The following is a description of a gene set: Human Gene Set: HP_CONCAVE_NASAL_RIDGE Concave nasal ridge Nasal ridge curving posteriorly to an imaginary line that connects the nasal root and tip. species: Homo sapiens, and this is the list of marker genes: NFKBIA, POU1F1, FBXL4, KDF1, DDR2, ZEB2, RECQL4, HSPG2, SOST, IL2RA, CANT1, IGF1, ANTXR1, DMXL2, FOXC1, STAT5B, EXOSC2 (NCBI Gene Id 23404), NIPBL, JAG1, PEPD, ATP6V1E1, EBP, SHANK3 (SH3 and multiple ankyrin repeat domains 3), SLC37A4